The following is a description of a gene set: studied in species Homo sapiens The lysosomal-vacuolar pathway has a role in the controlled intracellular digestion of macromolecules such as protein complexes and organelles. This feature refers to the presence of an abnormally increased number of autophagic vacuoles in muscle tissue. Human Gene Set: HP_AUTOPHAGIC_VACUOLES Autophagic vacuoles, and this is the list of marker genes: ACTA1, ACTN2, RILPL1, TNPO3, CRYAB, MYOT, LDB3, LRP12